Given this list of marker genes ROS1, TNR, MEG3, LEP, MAP2K5, HDGFL2, GJA1, XBP1, EPHX2, NET1, AVPR1A, ACVR1B, HSPA1A, CACNA2D2, ALOX15B (arachidonate 15-lipoxygenase type B), SOX15, CRYAB (crystallin alpha B), CDC73, PRDM11 (PR/SET domain 11), STAT5B, TLL2, JADE2, VIL1 (NCBI Gene Id 7429), SYT2, DCAF1, HNF1B, ULK2, MEF2C, RIMS2, OPA3, AKT1, DNPH1, HRG, FAM107A, CXCL12, CDKN2D, BMPR1A, FHL1 (four and a half LIM domains 1), TBX5, FGF2 (fibroblast growth factor 2), HOXB13, MSTN, EGFR, TNC, CRKL, DERL2 (NCBI Gene Id 95558), PRR5, OSTN, SEMA6C, EIF4G2, TSPYL2, INSR, BMP10, CGRRF1, DCSTAMP, MUL1, SEMA5A, JARID2, SGK2, KAZALD1, RPS6KA1, COLQ, TMEM196, IGF2, SPTBN4, SPP1, MT1M, FSTL4, TMEM97, MT2A, RGS2, DISC1, FRZB, ADRB1, TCHP, DRAXIN, TRIM32, PRLH, FGFR2, YBX3, FN1, SHTN1, SGPL1, HSF1 (heat shock transcription factor 1), PABIR1, CCAR2, ACACB, G6PD, CDK11A, WFS1, APP, RNF157, CLSTN1, SOD1, RNF6, MIR29B1, ERBB2, MIR19A, ERBB4, PAK1, SLC44A4, BAP1, DSCAM, AGTR1, SLIT3, TRPC5, EPHA7, SEMA3F, VPS54, SIPA1, ADRB2, AVP, EXOSC4, PSMD10, ADAM17, MT1E, BDNF, PRKCQ, RAB21, ANAPC2 (NCBI Gene Id 29882), RB1, CAPRIN2, PEX5 (peroxisomal biogenesis factor 5), TWF2, SYT1, VEGFA, ATRN, BBS2, EGLN2, MT1X (metallothionein 1X), STK3, TRIM40, NIPBL, CREB3, ATP8A2, CSF1, STC2, ABL1, RBBP7, CYBA, DCC, TMPRSS4, YAP1, TP73, YY1, GH1, LMX1A, RIMS1, FOSL2, ISLR2, BCL11A, CSNK2A1, NUBP1, CD38, NME6, MIR19B1, RASAL1, KIF26A, WWC1, APOE, MIR590, OLFM1, MIR208A, GPAT4, GDF5 (growth differentiation factor 5), TFRC, ZFYVE27, EFNA5, HPN, MYOCD, SYT3, RPTOR, SLC9A1, KIAA0319, PPIB, PSRC1, STAT3, MTM1, ADAM15, MMP14, CIB1, PRSS2, SELENOP, ZC3H12D, STK4, ATAD3A, ARHGAP4, GPC3, CFL1, GAMT, DDR1, HTRA2, GHRL, MYOD1, H3-5, EPPK1, CPNE9 (copine family member 9), MT1B, NPR1, SFRP1, PIK3CA, ITCH, MIR873, KCNK2, DRD2, MYH6, CREB1, CISH, RAB33B (RAB33B, member RAS oncogene family), IP6K2, CSNK2A3, DCUN1D3 (NCBI Gene Id 123879), LAMTOR2, SGK3, MUSK, INO80, MIR204, MSX1, CPNE5, MIR509-1, EZR, PTK6, CCN3, LATS2, CHD7, EXOSC9, DACT3, NKX6-1, LIN7B, GHSR, PTCH1, PRKN (NCBI Gene Id 8004), HLX (NCBI Gene Id 3142), RAI1, NPM1, CRLF3, MTPN, GJD4, SLC6A4, DUSP6, ACSL4, TBX2, TFCP2L1, SGK1, SPAAR, ESR2, SMURF1, CDKN1B, DDX49, MEAF6, SMO (smoothened, frizzled class receptor), WFDC1, IL2, PROX1, MIR1-1, ARHGEF11, RTN4R, EXTL3, ENPP1, ZFPM2, TAOK2, SMAD4, URI1, GPAM, N6AMT1, GRN (NCBI Gene Id 2896), MAPK14, NANOS1, S100A8, CDKN2C, ADAM10, INHBA, NRCAM, JADE1, RGS4, FLVCR1, ENO1, MIR200B, PLAC8, GDI1, STAT5A (signal transducer and activator of transcription 5A), NPPB, PML, PTEN, RTN4, FOXS1, FGFR1, NPY1R, SESN2, WRN, DUSP10, HMGA2 (high mobility group AT-hook 2), GPR21, BCL2, VGLL4, CDKN1A, BCAR1, P3H1, MUC12, NGF, MINAR1, CYP27B1, FOXP1, PARP2, PDZD11, NKX2-5, RICTOR, CRK, MAPK11, SEMA3A, POU3F2 (POU class 3 homeobox 2), BARHL2, GNG4, CPNE6, EIF4G1, PIM1, EDN1, ADNP, CDH4, GHR, NTN1, FTO, HEY2, SEMA3G, NOG, RUFY3, ZMPSTE24, TRPV2, FGF9, OSGIN2, IGFBP4, PPP1R9B, ACTN3, ING5, DDX3X (NCBI Gene Id 730543), TTL, SYT4, HYAL2, IST1, SASH3, ARMC12, MIR548C, BMPR2, MTOR, SIX1, CDK11B (cyclin dependent kinase 11B), MT1H, ARX, TP53, CDH1, RERG, SFRP2, OSGIN1, GHRHR, H3-3A, RASGRP2 (RAS guanyl releasing protein 2), RBPJ, CCDC85B, HSPA1B, KIF14, ING1, DNAJB2, CDC42, MIR199A1, SLC6A3, GHRH, MIR25, GOLGA4, ATG16L1, MIR222, BASP1, AGR2, TRIM46, TOMM70, WWC2, IL9, CRYAA (crystallin alpha A), SLC23A2, SEMA6D, FXN, CAPN3, P2RX5, IGFBP3, NRG1, CDK5, RACK1, SIX4, PPP2CA, ACVRL1, KLHL22, MYOZ1, KDM2B, BLTP1, GSK3B, TNFRSF12A, PLXNA4, BBS4, GSK3A, PPM1F, WNT3, SH3BP4, FGF20, SOCS2, HDAC3, DIP2B, COL14A1, PI16, MT1F, CGA, RYK, MAPT, NACA, LTBP4, H3-3B, MYL2, MT1G, SFN, PPARA (peroxisome proliferator activated receptor alpha), TGFB1, SIN3A, GATA6, SPAG9, CXCL16, MIR199B, HBEGF, WT1, EBAG9, SEMA4F, IL7, SESN1, CEP43, MIR17HG, ZPR1, TP53TG5, S100A9, DCUN1D5, SOX17, GLI1, NOTCH1, CDKN2AIP, SYT17 (synaptotagmin 17), CDK1, PTPRJ, BST2, CCNB1, EAF2, FGF8, AR, KRT17, MEGF8, DLL1, HDAC6, SPOCK1, BCL2L11 (NCBI Gene Id 150819), GDF15, TGFBR1 (NCBI Gene Id 7046), RPS6KA3, TLE5, TKT, TSG101, C8orf44-SGK3, PLAA, LAMTOR1, IGFBP1, SAV1, HYAL1, MAEL, SRF, SDCBP, BDKRB1, AFG3L2, JADE3, CDKL3, SPHK1 (sphingosine kinase 1), SERP1, FGF13 (NCBI Gene Id 730528), FBP1, SPART, ARMC10, SEMA7A, NDRG3, PAPPA2, ULK1, IFRD1, MLST8 (MTOR associated protein, LST8 homolog), GDF9, NPPC, IGFBPL1, TAF9B, ST7L, CACNG7, RFTN1, MBD5, MAD2L2 (NCBI Gene Id 10459), SUPV3L1, MACF1, IGFBP5, PHB1, ITSN2, CLSTN3, CRABP2, GNAS, MELTF, GAP43, PAFAH1B1, MAP1B, DAB2, RAG2, CTTN, SMAD3, HNF4A, BNIPL, STK11, CDA, CTDP1, CHPT1, PLXNA3, PAK5 (NCBI Gene Id 57144), LGI1, PTCH2, WWC3, L1CAM, NPPA, ING4, BCL6, TBX20, PLS1, UCN, LGMN, BRAT1, CEACAM1, RND2, CAMK2D, SUV39H1, SPHK2, KAT7, AGRN, NCBP1 (nuclear cap binding protein subunit 1), FGFR3, SERTAD2, SOCS6, AGT, RGMA, BRCA1, WNT5A, CDKL5, BCL2L1, NAIF1, INS, LPAR3, F2, BTG1, CDKN2A (cyclin dependent kinase inhibitor 2A), TGFB2, HOPX, RUNX1, DIO3, IL17RB, ADCY10, IGF1, NRG3, ZP3, SLIT2, SLIT1, LIN7A, SMAD7, PPARD, IHH, MYCBP2, MAP3K13, ZNF639 (zinc finger protein 639), ADRB3, PPT1, LATS1, NEDD4L, NRP1, MT3, RBP4, PUM2, OGFR, PAK4, SLC25A33, ADIPOR1, MFSD2A, LRP12, MAG, LIN7C, CDHR2, NTRK3, WNT3A, FOXC1, FOXC2, MAPKAP1, POU4F2, SMARCA2, LIMK1, HIF1A, AGTR2, TEAD1, PTPRS, MKKS (MKKS centrosomal shuttling protein), CLASP2 (NCBI Gene Id 440948), DCBLD2, DNM2, SYT14P1, TGFBR3, PLCB1, IGFBP7, SMARCA4, AKAP6, SEMA4D, SCGB3A1, WNT2, UNC13A, EI24, EXOSC2, MT1A, SERTAD3, EPM2A, PPP2R1A, CAV3, MAP2, SERPINE2, GDF2, CCNB2 (NCBI Gene Id 9133), here is a description of the gene set: Any process that modulates the frequency, rate or extent of the growth of all or part of an organism so that it occurs at its proper speed, either globally or in a specific part of the organism's development. studied in species Homo sapiens Human Gene Set: GOBP_REGULATION_OF_GROWTH